Given this list of marker genes Entpd8, Tk2, Upp1, Tyms, Adss1 (adenylosuccinate synthase 1), Shmt1, Dctd (dCMP deaminase), Nme2, Gmpr2, Gmps, Tk1 (NCBI Gene Id 21877), Rfk, Impdh2, Gmpr, Prps1, Uckl1, Ampd1, Ada, Ampd3, Cda, Umps, Cad, Nme1, Shmt2, Nudt2, Adsl, Uck2, Pfas, Impdh1, Upp2, Adss2, Aprt, Nme3, Ppat, Uck1, Dhfr, Hprt1, Dck, Uprt, Gart, Paics, Prps2, Dhodh, Adk, Pnp, Ampd2, Dut, Dguok, Atic, here is a description of the gene set: species: Mus musculus The chemical reactions and pathways resulting in the formation of a nucleoside monophosphate, a compound consisting of a nucleobase linked to a deoxyribose or ribose sugar esterified with phosphate on the sugar. Mouse Gene Set: GOBP_NUCLEOSIDE_MONOPHOSPHATE_BIOSYNTHETIC_PROCESS